The following is a description of a gene set: Mouse Gene Set: GOCC_NEURONAL_RIBONUCLEOPROTEIN_GRANULE A ribonucleoprotein complex that is found in the cytoplasm of axons and dendrites, and transports translationally silenced mRNAs to dendritic synapses, where they are released and translated in response to specific exogenous stimuli. studied in species Mus musculus, and this is the list of marker genes: Eif4ebp2, Uhmk1, Pqbp1, Kif3c, Hnrnpab, Htt, Ckap5, Arc, Hnrnpa2b1, Fmr1